Given this list of marker genes ODAPH, TFAP2A, ENAM, AMTN, CFTR, AMELX, WNT6, SLC4A2, here is a description of the gene set: Human Gene Set: GOBP_POSITIVE_REGULATION_OF_TOOTH_MINERALIZATION Any process that activates or increases the frequency, rate or extent of tooth mineralization, the deposition of calcium salts in tooth structures. studied in species Homo sapiens